The following is a description of a gene set: Any process that stops, prevents, or reduces the frequency, rate, or extent of mast cell activation. species: Mus musculus Mouse Gene Set: GOBP_NEGATIVE_REGULATION_OF_MAST_CELL_ACTIVATION, and this is the list of marker genes: Cd84, Rabgef1, Cnr1, Ptpn6, Lilrb4a, Enpp3, Cd300a, Cd300lf, Milr1, Cnr2, Fer